The following is a description of a gene set: studied in species Homo sapiens Enables the transfer of carnitine across a membrane. Carnitine is a compound that participates in the transfer of acyl groups across the inner mitochondrial membrane. Human Gene Set: GOMF_CARNITINE_TRANSMEMBRANE_TRANSPORTER_ACTIVITY, and this is the list of marker genes: SLC22A4, SLC6A14, SLC16A9, SLC25A20, SLC22A5, SLC22A1, SLC22A16